Given this list of marker genes Casp1, Naip2, Naip5, Naip1, Nlrc4, Naip6, here is a description of the gene set: studied in species Mus musculus An inflammasome complex that consists of three components, IPAF, NAIP and caspase-1, and includes among its functions the sensing of flagellin derived from Legionella pneumophila, Salmonella typhimurium, Pseudomonas aeruginosa and Shigella flexneri. Mouse Gene Set: GOCC_IPAF_INFLAMMASOME_COMPLEX